Given this list of marker genes GPR143, LAMB2, OCA2, CHM, FOXC1, TSC2 (NCBI Gene Id 7249), TRIM44, SOX10, IFNG, SLC25A15, TYR, EDNRB, MTTP (NCBI Gene Id 4547), SLC45A2, PAX6, MITF, EPG5, TSC1, GUCY2D, COL4A1, BLOC1S6, CACNA1F, KIF7, MC1R, PRPH2, PAX3, GUCA1A, GGCX, here is a description of the gene set: Hypopigmentation of the fundus studied in species Homo sapiens Reduced pigmentation of the fundus, typically generalized. Fundoscopy may reveal a low level pigment in both RPE and choroid with clear visibility of choroidal vessels (pale/albinoid) or low pigment level in the RPE with deep pigment in choroid so that visible choroidal vessels are separated by deeply pigmented zones (tesselated/tigroid). Human Gene Set: HP_HYPOPIGMENTATION_OF_THE_FUNDUS